The following is a description of a gene set: studied in species Homo sapiens Human Gene Set: AREB6_02 Genes having at least one occurrence of the motif WNWCACCTGWNN in the regions spanning 4 kb centered on their transcription starting sites. This matches the TCF8 transcription factor binding site V$AREB6_02 (v7.4 TRANSFAC)., and this is the list of marker genes: SH3RF1, GNAT1, DNAJB5 (DnaJ heat shock protein family (Hsp40) member B5), HRH3, GRIK4, DOCK4, GABRA3, KCNK16, KBTBD8, AFF3, PRDM1 (PR/SET domain 1, NCBI Gene Id 639), GJB1, PABPN1, WT1 (NCBI Gene Id 7490), IGF1, KHDRBS2, SLC6A7, GPRIN1, DCDC1, S100A1, EDN1, EFNA1, SYT3, POU3F4, GNA14, C6orf62, PCP4, VGF, TIMM10B, MAP2K6, JADE1, ANKHD1-EIF4EBP3, AHI1, USP48, UNC45A, KIF13A, CYSTM1, BCL2L1, PAX3, FDPS, ZNF296, GRID2, CHRM1, GDNF, ZNF467, IRX4, DTNA, CAVIN2, PLA2G4D, CREBZF, POLR1D, LRCH4 (NCBI Gene Id 4034), HMGCS1, FOXL2, NRP2, WT1-AS, GABRQ, PCDH1, UBAP2L (NCBI Gene Id 9898), ZNF277, SPPL3, IKZF2 (IKAROS family zinc finger 2), ZFHX3, TXNDC12, ITGA3, GGN, DLL4, LMNTD2, LLGL2, POU2AF1, SOX10, PTF1A, GPR87, LY6G6C, NRXN3, ARFIP2, RTN1, WNT6, PDE7A, FOS, DDAH2, KDM3B, FOXA1, ATF2, SCN5A, GADD45A, GPR174, DDR1, MYO18A, EDEM3, LGI2, WNT10B, AXIN2, CRAT (NCBI Gene Id 1384), BZW2, IL13RA1 (interleukin 13 receptor subunit alpha 1), CPNE1, TMEM151A, HNF1B, WDPCP, RBM39, HPSE2, NYAP1, HOXD3, EHF, ARMC8, MAPK10, UBE2D1, SAMD12, DMD, SPEG, DNMT3A, ADGRG3, SPTBN1, TUBA4A, EGLN3, KCNH5, ADAM11, CTCF, ARHGAP44, DCTN1, ING3, DNAJC13, FLNB, FADS3 (fatty acid desaturase 3), UBXN10, WFIKKN2, OTUD7B, MUSK, SMG1, PIK3R1, AMPD1, VKORC1L1, ERBB4, SHH, APEH, SEMA3A, S100A16, TSPAN8, SPA17, SH2D6, DRP2, FBXO24, UCHL5, ZC3H10, FAM81A, LPCAT3, LNX2, FSHB, POU4F1, RIMS1, TRIB1, OTX1, MTMR4, NRF1, DMPK, FBXL19-AS1, IP6K2, LMO2, WWP2, MAP3K5, GPX1, NKX2-1, ETV3, TMEM88, PLAG1, GUCY1B1, USP37, KCNIP4, SLC16A8, CDH13, DDX4, IRF2BPL, EPN2, NOVA1 (NOVA alternative splicing regulator 1), BMF, RNASE4, UBE2E1, TUBA4B, WBP2, SOX4, VAT1, CTPS2, COX6A2, FNBP1L, TDRD3, ROGDI, TBX19, NOL4, STAG1, TSPAN33, TAGLN2, CADM2, EYA2, SLC12A6, RBFOX2, TMEM150A, DLG2, HYPK, NTF3, CCDC106, FAM78A, SOSTDC1, MAP7, MYL3, NBEA, GRIK3, TAB2, SRSF7, KCNG3, RFFL, CLDN7, CSF3, OCLN, PISD (phosphatidylserine decarboxylase), RUNX1T1, DENND4A, SIAE, RO60, ANKHD1, ERBB3, SH3GL2, SLC6A9, PRPH, DGKG, TUBA1C, PITX2, RGMA, RRAGC, USP1, USP2, ARMCX2, RAB5B, TMEM139, NECTIN4, LCP1, WNT9A, FAM131A, DNASE2B, CAMKK1, YARS1, BCL6 (BCL6 transcription repressor), ZHX2, GPR158, COL11A2 (NCBI Gene Id 494120), PGM2L1, CNOT9, OSR1, TMEM62, OMG, S100A14, MTMR11, PTPA (protein phosphatase 2 phosphatase activator), CCDC140, HNF4A (NCBI Gene Id 4339), HES7, SLC23A3, LAMC2, PROX1